The following is a description of a gene set: Human Gene Set: GOBP_WNT_SIGNALING_PATHWAY_CALCIUM_MODULATING_PATHWAY species: Homo sapiens A type of non-canonical Wnt signaling in which Wnt binding to its receptor on the surface of a target cell leads to an increase in intracellular calcium and activation of protein kinase C (PKC)., and this is the list of marker genes: FZD4, WNT5A, DKK1, NLK, WNT11